The following is a description of a gene set: studied in species Homo sapiens Binding to cyclins, proteins whose levels in a cell varies markedly during the cell cycle, rising steadily until mitosis, then falling abruptly to zero. As cyclins reach a threshold level, they are thought to drive cells into G2 phase and thus to mitosis. Human Gene Set: GOMF_CYCLIN_BINDING, and this is the list of marker genes: USP2, PROCA1, CDK13, CDK14, CDK2, KLHDC9, CDK6, CDK1, CDK12, HDAC3, MDFIC, CIZ1, CDK15, PTCH1, CUL3, NDC80, POLN, XRCC6, TNFAIP1, FBXO31, GAK, CDKN1A, INCA1, FBXW7, CDK4, RACK1, UBE3D, CDKN1B (NCBI Gene Id 1027), CDK5RAP3, CRABP2, GPS2, INSM1, CDK3, RBM4